The following is a description of a gene set: species: Mus musculus Mouse Gene Set: GOBP_CALCIUM_ION_EXPORT_ACROSS_PLASMA_MEMBRANE The directed movement of calcium ions from inside of a cell, across the plasma membrane and into the extracellular region., and this is the list of marker genes: Slc8a3, Slc35g1, Ywhae, Slc8a2, Rgs9, Atp2b1, Slc24a4, Calm2, Atp2b3